Given this list of marker genes SDE2, POU3F2, FRG2, EPHA7, YAF2, ZNF664, ABCD2, RBM4, GK, GADL1, ZNF148, CD164, DUSP4, FAM3C, TPM4, NEMP1, PGAP6, EVI2B, DOCK9, C5orf47, SLC22A24, GCLC, RHBDD1, DPP4, KCTD9, AUTS2 (NCBI Gene Id 26053), CCDC125, ADD3, LRP1B, HIPK1, ZNF644, GLI2, YTHDC1, VIP, ARL14EP, STRN, NAMPT, ARL6IP6, USP47, FRMD5, FYB2, LONRF3, UBXN4, TRHDE, RGS5, DNAH8, NUFIP2, RORA, CSRNP1, PAPSS1, PSMA2, PTGER3, TOGARAM1, YWHAQ, CFAP20DC, CFDP1, VEGFA, STC2, NSMAF, PEA15, NUP133, SCN9A, RUFY2, PPBP, SENP5, SRPK1, PCSK6, SLC26A11, FHL1, SRSF9, VCF2, MEDAG, FRG2C, NKAIN2, MEX3B, SMAD5, KLHL31, SNX20, RUNDC3B, SP4, CDK8, SUB1, CLCN3, PTPN22, NAALADL2, HSD17B11, MREG, AADAC, FAM241A, WDR5, DDX5, GALNT11, LSM8, SLC12A1, DCUN1D1, FKBP7, SEMA3E, ZFP64, KRT222 (keratin 222), ADGRB3 (adhesion G protein-coupled receptor B3), ADGRL3, CASZ1, INSM1, BTBD3, TSPYL5 (TSPY like 5), PRKCB (protein kinase C beta), MTMR2, here is a description of the gene set: from publication Chen Y, Wang X (PMID 31504780) Human Gene Set: MIR3668 Genes predicted to be targets of miRBase v22 microRNA hsa-miR-3668 in miRDB v6.0 with MirTarget v4 prediction scores > 80 (high confidence targets). studied in species Homo sapiens